The following is a description of a gene set: studied in species Mus musculus Mouse Gene Set: GOBP_POSITIVE_REGULATION_OF_SPINDLE_CHECKPOINT Any process that increases the rate, frequency, or extent of the spindle checkpoint, a cell cycle checkpoint that delays the metaphase/anaphase transition until the spindle is correctly assembled and oriented, and chromosomes are attached to the spindle., and this is the list of marker genes: Dync1li1 (NCBI Gene Id 93741), Pcid2, Xrcc3, Cdca8, Mad2l1, Aurkb, Birc5, Ndc80, Knl1, Incenp, Gen1, Tpr, Mad1l1